The following is a description of a gene set: Mouse Gene Set: GOBP_GONADOTROPHIN_RELEASING_HORMONE_NEURONAL_MIGRATION_TO_THE_HYPOTHALAMUS The directional movement of a gonadotrophin-releasing hormone producing neuron from the nasal placode to the hypothalamus. studied in species Mus musculus, and this is the list of marker genes: Plxna3, Sema3e, Plxna1, Nrp2, Ndnf, Nrp1, Sema3a